The following is a description of a gene set: species: Homo sapiens Human Gene Set: GSE38304_MYC_NEG_VS_POS_GC_BCELL_DN Germinal centers (GC) arise within B cell follicles upon antigenic challenge. In the dark zones (DZ) of GCs, B cells proliferate and hypermutate their immunoglobulin genes, and mutants with increased affinity are positively selected in the light zone (LZ) to either differentiate into plasma and memory cells, or re-enter the DZ for further refinement. However, the molecular circuits governing GC positive selection are not known. Here, we show that the GC reaction requires the biphasic regulation of c-MYC expression, involving its transient induction during early GC commitment, its repression by BCL6 in DZ B cells, and its re-induction in a subpopulation of positively selected LZ B cells destined to DZ re-entry. Accordingly, acute disruption of MYC function in vivo leads to GC collapse, indicating an essential role in GC physiology. These results have implications for our understanding of GC selection and the role of MYC deregulation in B cell lymphomas. We used microarrays to determine the global gene expression programs that distinguish MYC+ GC B cells from their MYC- negative counterparts. Genes down-regulated in germinal celter B lymphocytes: MYC- versus MYC+. from publication Dominguez-Sola D, Victora GD, Ying CY, Phan RT, Saito M, Nussenzweig MC, Dalla-Favera R (PMID 23001145), and this is the list of marker genes: THTPA, ENPP1, MAFG, ELOA, TRMT112, RECK, ADORA2A, NDUFB7, BEX2, NDNF, COQ3, SURF1, GNG2, SERPINB1, C15orf40, GBP4 (NCBI Gene Id 115361), POLD3, SLAMF7, CDC25B, LGALSL, CRCT1, ART3, ZNF239, CYB5R4, RAB39B, VKORC1, YWHAQ, MCOLN2, GNA15, SYTL3, CAPN2, CDK5RAP3, ZSWIM5, PRDX2, PKP4, SEC61B, RUNX2, ARL6, ZDHHC2, GCNT1, PIM1, NMRK1, DSTN, EID2, POLR2K, ABR, HIGD1C, B3GNT5, PCGF2, CEMIP2, PTGER2, BCL2A1, ST3GAL6, TREML4, CCL20, IL12RB1, RNF157, TTC39C, TRAF5, FAM241B, PPP3CC, EEA1, ST6GALNAC4, IFNG, GARIN3, TPST2, CYSLTR2, SNTB2, RILPL2, SORL1, BOLA2, LYSMD2, B3GAT3, AP3M2, ANXA1, YBX3 (NCBI Gene Id 8531), ICOS, GPR34, SLC2A8, DEAF1 (NCBI Gene Id 105376508), BAG3, TMEM109, FLOT1, SMPDL3B, ZCCHC3, WDFY2, CAMK2N1, CD44, AKNA, KATNB1, POLR2E, CCDC92, ANXA2, NAT10, MTHFS, IL2RB, POU6F1, GPR155, KCNC2, RINL, EI24, TMT1A, RNH1, NIBAN1, ORAI3 (NCBI Gene Id 93129), NCF4, ID2, EMC10, LDAF1, LITAF, HSD11B1 (hydroxysteroid 11-beta dehydrogenase 1), MAF, GRN, ELAC1, BAIAP3, NCALD, DHDH, PRKAR2A, CTSW, CCDC9, ALAD, RHOC, GPM6B, POGLUT2, IL1R1, PRR13, APOBR, VAMP5, RNF125, ITGB1, MRPL54, CCHCR1, TBC1D1, SEMA4F, EFHD2, CCDC91, RPA2, LRRC8D, DMRTA1, APOBEC3B, SCAMP3, NRARP, TLR3, TPI1, AP1G2, TBKBP1, NUDT22, HOPX, REPIN1, DNAJC15, RAB20, HOOK2, B3GNT2, PARP16, TJP2, ELL2, LIN37, ST14, ADIPOR2, PLSCR1, PPP1R14A, MAPRE2, GPR183, NUCB1 (nucleobindin 1), ARHGAP26, OSTF1, TJP3, STX11, C19orf38, DECR1, PRNP, TMOD3, PTTG1, IFITM10, SCPEP1, GBE1, CHAC2, POGK, IFNAR2, LIME1, GALM, LPXN, PDE2A, TRAF1 (TNF receptor associated factor 1), STIMATE, CRMP1, ANGPTL2, GALNT9, ASNS, COBLL1, MED29, SIL1, CRYBG3, IFNGR1, ENDOD1, ZBTB42, CIBAR1, SHLD1, SLIRP, EMP1